The following is a description of a gene set: Human Gene Set: HP_WOLFF_PARKINSON_WHITE_SYNDROME species: Homo sapiens A disorder of the cardiac conduction system of the heart characterized by ventricular preexcitation due to the presence of an abnormal accessory atrioventricular electrical conduction pathway. Wolff-Parkinson-White syndrome, and this is the list of marker genes: MT-CO2, GTPBP3, MT-TQ, MT-TS2, MT-CYB, BMP2, TSC2, FNIP1, MT-ND1, MT-ND5, MT-TC, MT-CO1, IFNG, MRPS14, NDUFAF1, TNNI3, JAG2, TCAP, MT-TK, MT-TF, MT-TH, ATP1A3, MT-TV, MTFMT, LAMP2, PRKAG2, TSC1, MT-TW (NCBI Gene Id 4578), GAA, MT-ND6 (NCBI Gene Id 4541), MT-CO3, MT-ND4, MT-TL1